The following is a description of a gene set: Mouse Gene Set: GOBP_SYNAPTIC_VESICLE_ENDOSOMAL_PROCESSING The process in which synaptic vesicles fuse to the presynaptic endosome followed by sorting of synaptic vesicle components and budding of new synaptic vesicles. species: Mus musculus, and this is the list of marker genes: Rab7, Gripap1, Btbd8, Ap3d1, Itsn2, Bcl2l1, Dnm1l, Vamp4, Ap1s2, Vti1a, Stx12, Myo5b, Stx7, Itsn1, Stx6